Given this list of marker genes DCN, EIF4EBP1 (NCBI Gene Id 1978), OSBPL1A, ABHD12, MMP24OS, FHOD3, ELOVL2-AS1, DPYSL3, SMAGP, C1S, SLC9A7, HACD4, ANO1, TBCB, FARP1, NUF2, FKBP9, LTBP2, BACE2, PRICKLE1, NIPAL3, SNRNP25, KDM1B, NREP, JPT1, PTN, PKM, SIX1, CDC7, GPC1, COL5A2, TUBB6, IFIT2, CNTN3, PTGIS, TUBB4B (tubulin beta 4B class IVb), LRRC17, PPARG, UBR7, SSPN, MYLK, KIAA0930, NIPSNAP3A, ADGRG6, CAV1, POGLUT3, TUBA1C, PLPPR4, TSPAN5, DOK5, ACTN4, ARNT2, RABGAP1L, EPHB2 (EPH receptor B2), SPTBN1 (NCBI Gene Id 91654), FLOT1, ACTG2, CTHRC1 (collagen triple helix repeat containing 1), SNX7, PDLIM7, LPP, GALNT10, DTX3L, JDP2, B3GALT2, HEATR9, RASSF2, NRP1, IL17RD, RTL8C, LOXL1-AS1, WASHC3, FBN2, OSBPL3, SGCD, PXK, HIC1, C7, PRIM2, NFIX, APOL6, MCM6, SPATS2L, SMPD1, DHCR24, SLC7A14, ADH1B, TOX, FBLN1, RNF115, CD9, SCN9A, SERPINH1, HIVEP3 (NCBI Gene Id 86368), CCNE2, LIMS2, HHEX, GPRC5B, BRIP1, ZNF469, AGA, MDK (NCBI Gene Id 4192), GPC6, MTCL1, AS3MT, LMOD1, EPHA4, SCN7A, GATA6, IRAG1, FLNA, TRPV2, UTRN, LACTB, CNN1, CCN4, PAK1, RBP1, ANXA2, TWIST1, CD200, ADD1, F2RL1, RELN, MELK, HOXB-AS3, ABAT, GBP1 (guanylate binding protein 1), CAVIN3, CYTOR, ANXA2P2, CEP15, MSRB3 (NCBI Gene Id 253827), PDGFD, ARRB1, IFITM3, EVL, CDCA7, SAMD9L, CDC42EP5, LMO7, CNN3, PEAR1, ABI3BP, TMEM176A, AK5, C1R, OLR1, CD44, RASSF3, TGM2, QPRT, AQP3, CORIN, GALNT5, MYH9, TMTC2, NPTX1, WDR41, NIBAN1, SLC7A5 (solute carrier family 7 member 5), TUBB2A, GPRC5A, KIF11, PSPH, GMDS, UGCG, TP53I3, CXCL12, NT5DC2, CEP55, PDE5A, PSG1, DEPP1, PRKAG2, CPE, TMTC1, PLIN3, EHD1, RAB40B (NCBI Gene Id 10966), NOTCH2, LIMD1, DHRS3, SARS1, STEAP3, NALCN, NLRP1, SLC14A1, SEMA3C, BMP4, APCDD1, CLEC3B, CYB5A, NMI, SYT1, AHNAK, ITGA6, DIAPH3, SLC66A3, ASS1, CDKN2A, ANPEP, NXN, SPARC, LOXL1, WARS1, DPF3, APOBEC3B, MATN2 (matrilin 2), KCNN2, SBF2-AS1, MAMLD1, FRMD5, CADM1 (cell adhesion molecule 1), SCARA3, SHMT2, TSLP, ADAMTS8, RGMB, FGD6, USP44, PSG5, GASK1B, CREB3L1 (NCBI Gene Id 90993), CDH6, RRAS2, MOXD1, MAP1A, VGLL3, RUNX1T1, SLC7A1, ANGPTL2, MINDY2, BEND6, S100A6, STXBP6, ARL4A, POSTN, UBE2V1P3, ZNF703, FCRL5, HMGA1, STK17A, SESN3, RGS10, LXN, MTUS1, PKIB, UHRF1, HEG1, FN1, EVA1A, ZYX, PDGFRL, NUPR1, XYLT1, NRXN3, NR2F2, KCNMB2, CAVIN1, TRIOBP, CARD10 (caspase recruitment domain family member 10), DEFB106A, RARRES1, CAMK2N1, PRIM1, RGS17 (NCBI Gene Id 26575), JADE1, CPM, SDC4, MN1, NR3C2 (NCBI Gene Id 4306), CORO1C, CHN1, BAALC, MFGE8, TPM1, LOXL2, TNFSF4, COL3A1, ANXA2R-OT1, LAMA4, EFEMP2, GPX4, TMEM47, LARP6, WWOX, COL6A2, OPN3, HSPB6, RAD51AP1, MEST, NFE2L3, VAT1L, TNS3, ASNS, CBS, TLN1, COL6A1, ICA1, ALDH1A3, SPOCK1, HBD, S100A4, CNN2, SLC2A4RG, BMPER, OLFML2A, RWDD1, COL1A2, INHBE, GARS1, CLIP3, MTHFD2, FAP, SULF1, TUBB, TUBA1B, EMP3, ATP2B4, HCFC1R1, TMT1A, KRTAP2-3, FZD2, POLE2, RHOJ, ADAMTS2, NAV2, MFAP4, ANO4, MIR155HG, CLDN11, MACROH2A1, VIM, FBN1, GAS6, KCTD16, SHROOM2, ANXA1, PRSS12, TMEM97, CCDC80, OPTN, TENT5C (NCBI Gene Id 54855), RSBN1L (NCBI Gene Id 222194), COL15A1, MAGI2-AS3, PMP22, SMAD3, ALPK2, COL1A1, NNMT, CD81, GALNT15, HSPB1, ARL4C, RASSF4, GDF5, CROT, MAP1B, MYOF, ACTA2, AXL, MAB21L2, MAP3K7CL, NUDT7, SYTL2, MTSS1, SRD5A1, IDH2, FOXL1, SH3BP4, PARP9, LIN7A, EXOG, AK1, CAPZB, TIMP2, ZFP36L2, VSIR (NCBI Gene Id 64115), ROR1, EHD2, COTL1, TMEM35A, GNAI2, DCTN3 (dynactin subunit 3), TNFRSF19, LINC02861, PTCH1, SLC1A4, UACA, THBS1, BCL7C, MPRIP, KRTAP1-5, THY1 (Thy-1 cell surface antigen), TIPIN, TRNP1, TMEM200B, DOCK10, HPGD, ELOVL2, SDC3, CAV2, SYNC, ADAM19, TP53TG1, ITGA5, TRIM14, OXTR, ATP8B1, ANXA6, MYL9, TYMS, TMEM171, CNTNAP1 (NCBI Gene Id 8506), CD99, LBH, ITGA4, MCUB, KCNMA1, LOX, RAB3B, UBE2V1, DENND1B, MECOM (MDS1 and EVI1 complex locus), SFRP1, CNKSR3, ERRFI1, RPL22L1, SRI, S100A10, PTGER2 (NCBI Gene Id 63381), C12orf75, MVP, STMN3 (NCBI Gene Id 50861), CMBL, WNT2, PXN, IFITM2, AFF3, C18orf54, GSTM1, PCLAF, PBOV1, FAM171B, SERPING1, OLFML3, MCM5, RHBDL2, LHFPL6, PCOLCE, PRAG1, PALLD, TRAPPC1, PSMB9, DDX60, ECM1, CTSH, PTX3, TUBA1A, SYNPO2, KLF7, ACOT7, DIPK1A, FRZB, EPB41L2, TRAM2, IL32, SGMS2, MAN1C1, CAMK2D, KCNH2, IFI16, TMEM106C, DUBR, PSG4, TJP2, FHL2, SIPA1L2, LOXL4, TOX-DT, WDR1, DAB2, LMNA, PPM1M, COPZ2, ADGRA2, ANKRD13A, NMT2, BGN, MRGPRF, TAGLN, CHEK1, RNF128, FOXD1, WNT5B, SYNPO, PHGDH, CHML, ACTB, SNN, LIPA, FRY, GBP2, CLU, SNTB2, TSPO, TAC3, PIK3R3, ITGBL1, G6PD, SPOCD1, COL5A1, SPX (NCBI Gene Id 80763), RBMX, SCUBE3, PCK2, THSD4, PIK3R2, IGFBP6, PEA15, PSAT1, FOXC2, NES, PRDX6, SERPINF1, FMO3, PRSS35, BLVRB, MCM4 (minichromosome maintenance complex component 4), EPG5, TES, TUBB2B, XAF1, ARHGAP1, MGARP, CXXC5, SKA2, PLEKHG4, CARHSP1, GSN, SYNE3, ATP6V0E2, SH3BGRL3, RAP1GDS1, CAND2, PRSS23, TCEA3, TPM2, NTN4, HELLS, CAPG, LY6E, NAV3, TGFBR2, SERPINE1, TMED4, VCAM1, PRPS1, HOXB5, PDLIM1, CDC42EP3, ARHGAP18, TENM4, TPT1-AS1, JAZF1, here is a description of the gene set: species: Homo sapiens The RB protein family (RB, p107, and p130) has overlapping and compensatory functions in cell-cycle control. However, cancer-associated mutations are almost exclusively found in RB, implying that RB has a nonredundant role in tumor suppression. We demonstrate that RB preferentially associates with E2F target genes involved in DNA replication and is uniquely required to repress these genes during senescence but not other growth states. Consequently, RB loss leads to inappropriate DNA synthesis following a senescence trigger and, together with disruption of a p21-mediated cell-cycle checkpoint, enables extensive proliferation and rampant genomic instability. Our results identify a nonredundant RB effector function that may contribute to tumor suppression and reveal how loss of RB and p53 cooperate to bypass senescence. from publication Chicas A, Wang X, Zhang C, McCurrach M, Zhao Z, Mert O, Dickins RA, Narita M, Zhang M, Lowe SW (PMID 20385362) Genes up-regulated in confluent IMR90 cells (fibroblast) after knockdown of RB1 by RNAi. Human Gene Set: CHICAS_RB1_TARGETS_CONFLUENT